The following is a description of a gene set: Human Gene Set: MODULE_484 Genes in the cancer module 484. studied in species Homo sapiens, and this is the list of marker genes: RPL27, SIPA1, SNX17, MOB3A, CORO1A, RPL37, RAC2, ARHGDIB, FAM32A, SPPL2B, TRAP1, PKN1, RPS9, LIMD2, GRK2, MAP4K2, GMEB2, SYK (NCBI Gene Id 6850), SURF1, ARHGEF1, LSP1, DOCK2, TAFAZZIN, NBEAL2, LDHB, CCND3, HDAC7, NCF1C, RAB4B, CYFIP2, TYK2, ISG20, NUMA1 (NCBI Gene Id 4926), DECR1, SOCS7, INPP5D, UCP1 (uncoupling protein 1), SYVN1, HP1BP3, ABTB1, NME3, RPLP2